The following is a description of a gene set: The lipid bilayer surrounding a recycling endosome. Human Gene Set: GOCC_RECYCLING_ENDOSOME_MEMBRANE species: Homo sapiens, and this is the list of marker genes: RAB17, ABHD17A, ATP9A, STX12, SYT11 (synaptotagmin 11), RAB12, ATG9B, HLA-C, SCAMP2, MICALL1, HLA-B, EHD3, RAP2C, ACAP1, ATP11C, ENTREP1, SCAMP1, RAB13, SLC9B2, BOK, SORL1, ATP13A3, OPTN, RAP2A, ATP11B, ZDHHC2, RAB35, HLA-H, VTI1B, VAMP8, NSG1, TPCN1, GGA3, RAB11FIP5, HLA-G, NEU3, ZFYVE27, HLA-E, SLC9A7, LAMP5, SLC39A4, HLA-F, SCAMP4, ABHD17B, EHD4, CFTR, CD274, BAIAP3, SLC26A7, RAB10, SLC36A2, VAMP3, WASH6P, TFRC, SLC11A2, GRIPAP1, RAC1, SLC31A1, LZTR1, WASH3P, ATG9A, RAP2B, PDIA3, EHD1, RAB8B, PACSIN2, RAB4A, B2M, RAB11FIP3, SYT5, SCAMP5, STX6, ABCB11, SLC9A3, GRIA1, NTRK1, SLC9A6, CMTM6, NDRG1, RAB11B, SLC1A1, ABHD17C, WASHC1, HLA-A, MTMR4, RAB11A, PLEKHB2, SLC30A10, CLCN4, INPP4A, ARF6, PDLIM4, CLIP3, DYNC1LI1, SORCS2, ATP13A4, RAB14, RAB11FIP2, VPS13B, MCOLN2, SCAMP3, RAB11FIP4, SLC9A5, FZD7, RAB8A (RAB8A, member RAS oncogene family), EHD2, SLC9A9, RFFL, SNX18